The following is a description of a gene set: The gene expression program underlying the specification of human cell types is of fundamental interest. The study authors generated human cell atlases of gene expression and chromatin accessibility in fetal tissues. For gene expression, the study authors applied three-level combinatorial indexing to >110 samples representing 15 organs, ultimately profiling ~4 million single cells. The study authors leveraged the literature and other atlases to identify and annotate hundreds of cell types and subtypes, both within and across tissues. Our analyses focused on organ-specific specializations of broadly distributed cell types (such as blood, endothelial, and epithelial), sites of fetal erythropoiesis (which notably included the adrenal gland), and integration with mouse developmental atlases (such as conserved specification of blood cells). These data represent a rich resource for the exploration of in vivo human gene expression in diverse tissues and cell types. Marker genes curated from the annotated cluster as represented in the Descartes Human Gene Expression During Development database. from publication Cao J, O'Day DR, Pliner HA, Kingsley PD, Deng M, Daza RM, Zager MA, Aldinger KA, Blecher-Gonen R, Zhang F, Spielmann M, Palis J, Doherty D, Steemers FJ, Glass IA, Trapnell C, Shendure J (PMID 33184181) Human Gene Set: DESCARTES_MAIN_FETAL_HEMATOPOIETIC_STEM_CELLS species: Homo sapiens, and this is the list of marker genes: FIRRE, PRSS57, ENSG00000222588, SPINK2, EOLA2, GALNT7-DT, KCNIP2-AS1, TARBP1, CD244, TM7SF3, UBR5-DT, BAALC, KLC4-AS1, IL12RB2, ENSG00000261638 (novel transcript), ENSG00000241525, IRAK3, HCG25, TFAP2E-AS1, CDCA7, TMCC1-DT, ELANE, RPS10P7, STAT5A, CDK6-AS1, EMC3-AS1, LRRC37A4P, SEPSECS, ENSG00000213963, LINC02987, ZP3, C1QTNF4, ENSG00000260316, AZU1, TRIM27, ENSG00000293341, LINC02100, LNCEGFL7OS, RPL21P10, RN7SL558P, ABCC1 (NCBI Gene Id 8133), SNHG3, FANCD2OS, TRIM66, CSRP1-AS1, CBX3P10, RFC4, LRRFIP1P1, MTND5P26, BMAL2-AS1, MIR3667HG, ZNF789, TAOK3, S100Z, LINC02328 (long intergenic non-protein coding RNA 2328), MPO, LINC02839, LINC02232, FASTKD1, GCC2-AS1, IQSEC3-AS2, DDTL, NRIP1, AOX2P, SPNS3, ENSG00000262482, RNU1-133P, PRTN3, MARS1, DENND3-AS1 (DENND3 antisense RNA 1), FAM216A, HSPE1-MOB4, DYTN, BAP1, NDUFAF6, PRAM1, EIF2S2P3, HSF5, TIPIN